The following is a description of a gene set: studied in species Mus musculus Carboxyterminal post-translational modifications of tubulin Mouse Gene Set: REACTOME_CARBOXYTERMINAL_POST_TRANSLATIONAL_MODIFICATIONS_OF_TUBULIN, and this is the list of marker genes: Ttll3, Tubb6, Ttll2, Tuba8, Ttll6, Tubb1, Ttll12, Ttll8, Tuba3b, Tubb4b, Tuba3a, Tuba1b, Tubb2b, Tubb3, Ttll10, Ttll5, Tubal3, Ttll9, Tuba4a, Ttll11, Tuba1c (NCBI Gene Id 22146), Tubb4a, Ttll7 (NCBI Gene Id 70892), Tuba1a, Tubb2a, Ttll13, Ttll4